The following is a description of a gene set: studied in species Homo sapiens Human Gene Set: MIR4429 Genes predicted to be targets of miRBase v22 microRNA hsa-miR-4429 in miRDB v6.0 with MirTarget v4 prediction scores > 80 (high confidence targets). from publication Chen Y, Wang X (PMID 31504780), and this is the list of marker genes: FOXQ1, CYTH1, ZC3H7B, BLCAP, RCN2, CNOT6, RASA1, FHIP2A, LMO3, CYP1A2, COPS2, GABPB2, CPED1, ATG14, ACOT7, ITSN2, SLC25A36, SERF1B, SNTB1, PLEKHA5, CPD, MANBA, NRXN1, ENTPD4, NR2C2, SEC63, ACBD3, PCDHA8, UMAD1 (UBAP1-MVB12-associated (UMA) domain containing 1), PDZD8, DTNA, NXT2, HYCC2, PCDHAC2, IRF6, RELL1, ITGB1, ADAM28, PCDHA4 (NCBI Gene Id 56144), ADIPOR1, RIT1, TNPO1, NCK1, DNER, IPO5, BOD1L1, EXO1, CDH20, PBX1, GTPBP2, MAGI1, ALOX12, DHDDS, SHCBP1 (NCBI Gene Id 79801), RAB14, BNIP3, EYA1, SATB2, ESRRG, MLF1 (myeloid leukemia factor 1), EIF2D, KLHL15, GRIK1, RBBP6, KCNS3, CDKL5, GNS, NAA20, ARFIP1, CNKSR2, HELZ, VHL, MTDH, RIOK3, PLPPR1, RHOBTB1, ITPK1, N4BP1, LHFPL3, RAI2, RBFOX2, CD274, RBMS3, TMEM64, MPPED2 (NCBI Gene Id 744), CPEB3, EOGT, ZBTB44, ARL8B, SESN3, DMXL1, PCDHA11, PDE1C, TRIM32, GOPC, SERF1A, GPCPD1, GXYLT1, SPPL2B, SLC9A2, NEGR1, FAM117B, ANKRD13A, RP2, DUSP16, ADCY3, SH2B3, PIK3CA, UBR3, GPBP1, GPRASP1, DISC1, PBX3, TIGAR, PCDHA2, MDGA2, HIVEP2, PCDHAC1, SMARCD2, KITLG, BAZ1A, GTF2A1, VEPH1 (NCBI Gene Id 79674), PCMTD1, SOAT1, ENY2, SDHD, USP46, PDK1, ONECUT2, YWHAH, ATL3, CNOT7, DYNC2H1, MTRF1, TBC1D15, FLRT3, ZKSCAN4, PPP1R3E, ABHD13, IPO7, CAPRIN1, NRP1, ETV1, MAPK9, STK26, TUSC3, PCDHA13, MAPK8IP3 (mitogen-activated protein kinase 8 interacting protein 3), RBPJ, YOD1, PCDH19, GSKIP (GSK3B interacting protein), PALM2AKAP2, PCGF5, ATP11A (NCBI Gene Id 84170), CD74 (NCBI Gene Id 972), TGOLN2, SEMA3A, RNF185, MLLT3, EMILIN2, ARF1, CFLAR, PAN3, USP25, MINDY2, BLOC1S5, BNC1, PCDHA9, RC3H1, CERT1, ARHGAP5, FEM1B, NUFIP2 (nuclear FMR1 interacting protein 2), LARS1, ZSWIM6, ARPP19, TC2N, COMMD3-BMI1, DCC, LZTS3, MTCL2, PCDHA5, ING5, EFS, PAK5, PCDHA12, AK4, DLX1 (NCBI Gene Id 1745), KLF5 (KLF transcription factor 5), HECTD2 (HECT domain E3 ubiquitin protein ligase 2), CXCL14, SAXO1, ATF7IP2, CREB5, NAP1L5, RBM24, TDP1, HIPK3, GABRP, PCDHA1, PHC3, TSC1, CNOT6L, NPAS2, SGCB, PELI2, FRRS1L, DCP1A, PALLD, FIGN, PCDHA6, CEMIP2, BRWD3, CYLD, VDAC1, DDX54, KLF13, ARMCX2, PHF1, IGF2BP3, PLXNC1, HSPH1, NABP1, PFKM, NETO1, CUX1, DCBLD2, TRIAP1, GNPDA2, ZDHHC3, TSHZ3, JMY, RNF138, NALF1, PCDHA7, TMEM108, TENT4B, SH3GL1, AGPS (NCBI Gene Id 8540), ABCC5, LRP6, CDK13, TMEM255A, SMNDC1, TFCP2L1, WDR19, GSPT2, TBX4, MCL1, MEX3B, ZNG1E, MXI1, DSCC1, HADH, PRPS1, AFF4, RAB18, GSPT1, FAM91A1, ACTL6A, CXXC4, AGFG1, MFSD14A, BHLHE41, SMAP1, GCG, PPM1B, PHC1, KLHL36, APPL1, TRABD2B, SOBP, LRRTM1, NRN1, ERMN, ZNF652 (NCBI Gene Id 22834), RAD21, IDS, TFAP2B, PCDHA10, JPT2, GNAI1, RBMXL1, CDH2, UTP14C, BMPR1A, WWC2, PIGK, IDE, ZNF281, ZNF670, ELL2, QSOX2, C6orf118, SPOPL, SAV1, PCDHA3, PRKCG, TMEM47, ELOVL6, PTGFRN, CD96, MAPDA, HSPA4, CANX, CDK6, CNTNAP5